The following is a description of a gene set: from publication Doering TA, Crawford A, Angelosanto JM, Paley MA, Ziegler CG, Wherry EJ (PMID 23159438) Human Gene Set: GSE41867_DAY8_EFFECTOR_VS_DAY30_MEMORY_CD8_TCELL_LCMV_ARMSTRONG_DN Genes down-regulated in CD8 T cells, acute infection with LCMV-Armstrong: effectors at day 8 versus memory at day 30. studied in species Homo sapiens During acute viral infections, naïve CD8+ T cells differentiate into effector CD8+ T cells and, after viral control, into memory CD8+ T cells. Memory CD8+ T cells are highly functional, proliferate rapidly upon reinfection and persist long-term without antigen. In contrast, during chronic infections, CD8+ T cells become “exhausted” and have poor effector function, express multiple inhibitory receptors, possess low proliferative capacity, and cannot persist without antigen. To compare the development of functional memory T cells with poorly functional exhausted T cells, we generated longitudinal transcriptional profiles for each., and this is the list of marker genes: FAM111A, HIP1R, COTL1 (NCBI Gene Id 90755), LYN, TADA3, SRSF6, ITPR1, AATK, CD19, FAS, PTCD2, CCR5, TMEM185A, LDAH, SLC6A13, NOP10, TTI1, CYRIB, RNF213, MRPL11, DAXX, TSR2, TCTN3, FCER1A, VPS37B, INPP5D, RARS2, PARD6G, LCMT1, NIT2, ARHGAP26, C19orf12, VASP, LPCAT2 (lysophosphatidylcholine acyltransferase 2), USP31 (NCBI Gene Id 57478), TNP2, WASHC1, MRPS26, PIP5K1C, PEX7, CDK9, PACRGL (parkin coregulated like), TATDN3, DPP9, SERPINB9, WARS2, SART1, ST6GALNAC4, CAMTA2, CELF2, PLEKHF2, ZSWIM8, C12orf43, PAGR1, GMIP, RCAN1, CEP63, IL21R, REST, ZBED5, PDE7B, DUSP2, ASCC2, DIMT1, VCPKMT, PANX1, PSMG3, NAGPA, NOTCH2, MGAT5, RSL1D1, ILF3, IFNGR2, RSF1, NOP16, CEP15, ARPP19, PDSS1, DLGAP4, NCOR2, SMYD5, MYH9, RECQL5, PREX1, USP19, DDX51, ADPRS, ABRAXAS1, AKAP7, TOR3A, MDN1, IKBKE, LNPEP, C15orf40, GPN1, DYNC1H1, NUFIP1, NAE1, CDCA7L, DENR, SLC19A1, ZFAND2A, KLF3, OLFM3, ZFP36L2, STAMBPL1, MYO9B, RRAGC, CYP8B1, AMDHD2, C7orf50, ARHGAP25, NFKB2, NTPCR, ISOC1, C8orf76, TRIM21, ZNF236, HERC2 (HECT and RLD domain containing E3 ubiquitin protein ligase 2), DAPP1, NUDT1, MSRA, ZEB2, GTF3A, ACTG1, DGKZ, LARP7, MFAP3, FAAP24, ANKFY1 (NCBI Gene Id 57500), ETNK1, OSGIN2, TCOF1, CLASRP, MEMO1, IL10RA, ROGDI, OSGEP, PYROXD1, POFUT1, LDB1 (NCBI Gene Id 8861), ISY1 (ISY1 splicing factor homolog), SNX10, HSPA8, TMEM131L, TMEM209, CLTA, PMS1, SPG7, TIMM10, COX7B2, CYB561A3, RBM34, SLFN13, MOV10 (NCBI Gene Id 57723), DHX58, NUP214, GATAD1, HSPE1, TFEB, DCP2, FHIP1A, GLMN, KEAP1, LRRK1, TGFB3, GPANK1, SPP1, ATP10A, CFP, MRPL21, BCL7A, SLC2A4RG (NCBI Gene Id 56731), N6AMT1, POLR3C, HYPK, HSH2D, NRM, EXOSC5, CLUH (clustered mitochondria homolog), PARP14, STK17B, PCNT, DEGS1, LACC1, MTPAP, ZDHHC13 (zinc finger DHHC-type palmitoyltransferase 13), PITHD1, OCIAD1, PRPF3, VPS33A, EMID1, GRIPAP1, SWAP70, NFKBIE (NFKB inhibitor epsilon), TLR6, ARB2A, SPIB, RHBDF2, KLHL14